Given this list of marker genes CAD, DTYMK, AK9, ENTPD5, ENTPD4, CMPK2, UMPS, CMPK1, DHODH, ENTPD7, here is a description of the gene set: The chemical reactions and pathways involving pyrimidine nucleoside diphosphate, a compound consisting of a pyrimidine base linked to a ribose or deoxyribose sugar esterified with diphosphate on the sugar. studied in species Homo sapiens Human Gene Set: GOBP_PYRIMIDINE_NUCLEOSIDE_DIPHOSPHATE_METABOLIC_PROCESS